Given this list of marker genes Akr1c18, Ifng, Rdh1, Rdh10, Isx, Rdh16f2, Cyp27b1, Snai2, Prmt3, Dgat1, Rdh19, Gfi1, Snai1, Nfkb1, Tnf, Rdh16 (retinol dehydrogenase 16), Cd320, Clybl, Rdh9, here is a description of the gene set: Any process that modulates the frequency, rate or extent of the chemical reactions and pathways involving a vitamin, one of a number of unrelated organic substances that occur in many foods in small amounts and that are necessary in trace amounts for the normal metabolic functioning of the body. studied in species Mus musculus Mouse Gene Set: GOBP_REGULATION_OF_VITAMIN_METABOLIC_PROCESS